Given this list of marker genes ERCC6, POLR3H, EIF2B2, C14orf39, NR5A1, PROK2, NR3C1 (nuclear receptor subfamily 3 group C member 1), BRAF, FIGLA, WDR11, GPR101, DIAPH2 (NCBI Gene Id 7989), BMP15, FGF8, MPV17, USP8, EIF2B1, ZSWIM7, FGFR1, MSH4, FANCM, WRN, LMNA, HS6ST1, ERAL1, EIF2B3, AIP, NUP107, PSMC3IP, POLG, KASH5, TP63, RCBTB1, SPRY4, SYCP2L, FSHR, PSMD12, SPIDR, CDH23, TBL1X, DUSP6, FOXL2, NHLH2, NSMF, LARS2, PRKAR1A, HSF2BP, FGF17, LHB, EIF2B4, ATRX, GNRHR, MEIOB, MRPS22, NOBOX, RNF216, KISS1, PPARG, TACR3, GNRH1, TKT, GALT, BNC1, TP53, BPTF, CHD7, HAMP (hepcidin antimicrobial peptide), TAC3, PAPSS2, PROKR2, KISS1R (KISS1 receptor), USP48, here is a description of the gene set: Human Gene Set: HP_SECONDARY_AMENORRHEA studied in species Homo sapiens Secondary amenorrhea